Given this list of marker genes INSIG1, SAR1B, AP3S2, TMED10, CTAGE8, SCAP, CTAGE1, SAR1A, RAB1A, AP3S1, SEC24C, AP3M2, MIA3, SEC24A (SEC24 homolog A, COPII coat complex component), CTAGE15, SEC31B, CTAGE4, CIDEB, CTAGE6, AP3B2, TBC1D20, KIF13A, SURF4, SEC31A, AP3B1, AP3M1, PICALM, SEC24D, SEC24B, MIA2, CTAGE9, AP3D1, SEC23B, SEC23A, SEC13, TMED2, here is a description of the gene set: The formation of a macromolecular complex between the coat proteins and proteins and/or lipoproteins that are going to be transported by a vesicle. species: Homo sapiens Human Gene Set: GOBP_VESICLE_CARGO_LOADING